The following is a description of a gene set: Human Gene Set: KEGG_MEDICUS_VARIANT_MUTATION_CAUSED_ABERRANT_SNCA_TO_ANTEROGRADE_AXONAL_TRANSPORT Mutation-caused aberrant SNCA to anterograde axonal transport. Pathway ID: N01055. Pathway type: Variant. Pathway class: nt06463 Parkinson disease. Pathway Definition from KEGG: SNCA* -| (KIF5+KLC) // (TUBA+TUBB) species: Homo sapiens, and this is the list of marker genes: TUBA3E, TUBB2A (NCBI Gene Id 92919), KIF5C, TUBB6, KIF5A, TUBB3, TUBA3D, KLC3, KIF5B, TUBA4A, KLC4, TUBB2B, TUBA1C, SNCA, TUBA1B, TUBB4B, TUBA1A (tubulin alpha 1a), TUBA8, TUBB, TUBB4A, TUBB1, TUBA3C, KLC1, KLC2, TUBB8